The following is a description of a gene set: The branch of the pentose-phosphate shunt which involves the oxidation of glucose 6-P and produces ribulose 5-P, reduced NADP+ and carbon dioxide (CO2). Mouse Gene Set: GOBP_PENTOSE_PHOSPHATE_SHUNT_OXIDATIVE_BRANCH species: Mus musculus, and this is the list of marker genes: H6pd, Pgd, G6pd2, G6pdx, Pgls